Given this list of marker genes OR7E15P, MILR1, TSPAN1, DHPS, RPP25L, ARHGEF10, ORMDL2, DNAJC17, EPHB2, FARS2, TTC7A, MARVELD1, CTC1, ERVMER34-1, MTRR, KLHDC2, HECTD3, PCK2, PIGV, EPB41L1, SLC6A14, ESAM, ALOX5AP (NCBI Gene Id 241), ACOT11, IFITM10, TENM4, GJA1, MARCKS, EYA2, MACROD1, HCAR1, ABCC3, SLC2A9, UNC93B1, LSM14B, NECTIN1, EOLA1-DT, HSD11B1, SYN3, OR7E21P (NCBI Gene Id 9432), DALRD3, TMEM126A (transmembrane protein 126A), RWDD2B, NBEAL2, CCNDBP1, DOCK10, ANKH (NCBI Gene Id 7995), PGAP2, SLC16A5, POLD4, SAMD15, OR5D14, HOOK2, ASB16-AS1, RPE, FOXP1, SPC24, FHOD3, TNS2, TRPT1, RFC1, ITPR3 (inositol 1,4,5-trisphosphate receptor type 3), here is a description of the gene set: Normal cells require continuous exposure to growth factors in order to cross a restriction point and commit to cell-cycle progression. This can be replaced by two short, appropriately spaced pulses of growth factors, where the first pulse primes a process, which is completed by the second pulse, and enables restriction point crossing. Through integration of comprehensive proteomic and transcriptomic analyses of each pulse, we identified three processes that regulate restriction point crossing: (1) The first pulse induces essential metabolic enzymes and activates p53-dependent restraining processes. (2) The second pulse eliminates, via the PI3K/AKT pathway, the suppressive action of p53, as well as (3) sets an ERK-EGR1 threshold mechanism, which digitizes graded external signals into an all-or-none decision obligatory for S phase entry. Together, our findings uncover two gating mechanisms, which ensure that cells ignore fortuitous growth factors and undergo proliferation only in response to consistent mitogenic signals. species: Homo sapiens Human Gene Set: ZWANG_EGF_PERSISTENTLY_DN Genes persistently repressed by EGF in 184A1 cells (mammary epithelium). from publication Zwang Y, Sas-Chen A, Drier Y, Shay T, Avraham R, Lauriola M, Shema E, Lidor-Nili E, Jacob-Hirsch J, Amariglio N, Lu Y, Mills GB, Rechavi G, Oren M, Domany E, Yarden Y (PMID 21596316)